The following is a description of a gene set: studied in species Homo sapiens Human Gene Set: MIR758_5P Genes predicted to be targets of miRBase v22 microRNA hsa-miR-758-5p in miRDB v6.0 with MirTarget v4 prediction scores > 80 (high confidence targets). from publication Chen Y, Wang X (PMID 31504780), and this is the list of marker genes: NUFIP2, TRIM37, DSG3, PTP4A1, ITPRID2 (NCBI Gene Id 6744), E2F5, SETD5, SLC20A2, BBS7, KAT2B, PSMF1, LOXHD1, TOX4, TBC1D32, RTKN, ID2, PHACTR1, CSNK1A1L, PLA2R1, TENT5D, RASA1, GSG1L, EEF2, VXN, SCYL2 (NCBI Gene Id 55681), OSBPL6, TET3 (NCBI Gene Id 23298), ZNF888, UQCRQ, LURAP1L, PTCH2, ZNF318, KLHL29, ULBP1